Given this list of marker genes SKIC3, SKIC2 (SKI2 subunit of superkiller complex), DIAPH1, PRKACG, TUBA8, GATA1, COG1, ITGB3, GFI1B, TUBB1, ACTB, TPM4, LBR, GP1BB, GP1BA, CD36, CDC42, MYH9 (NCBI Gene Id 65212), GNE, ITGA2B, ABCG5, GALE, ABCG8, ACTN1, FLNA, GP9, SLC35A1, FLI1, here is a description of the gene set: species: Homo sapiens Human Gene Set: HP_INCREASED_MEAN_PLATELET_VOLUME Increased mean platelet volume Average platelet volume above the upper limit of the normal reference interval.